The following is a description of a gene set: Human Gene Set: GOBP_REGULATION_OF_RESPIRATORY_GASEOUS_EXCHANGE studied in species Homo sapiens Any process that modulates the frequency, rate or extent of the process of gaseous exchange between an organism and its environment., and this is the list of marker genes: GSX2 (GS homeobox 2), GLS, ATP1A2, CC2D1A, NMBR, FTO (NCBI Gene Id 79068), GLRA1, PHOX2A, GRPR, MECP2, MTG1, NTSR1, PASK, PHOX2B, ADORA1, NLGN2, PBX3, MTG2, TSHZ3, GRP, NLGN3, TLX3, NR4A2, NMB